Given this list of marker genes ZDHHC15, GBP4, PLPP5, GEM, TRAF6, TP63, MIA2 (MIA SH3 domain ER export factor 2), ARF3, VAMP1, SF3B1, CALML4, WDR82, COBL, MAN1C1, ZNF566, MAP3K8, RNF145, TGFBR3L, MACC1, DPP8, ETV1, IRF2BP2, NALCN, ADGRF5, CDY1B, NSD2, GUCY1A1, SLC2A1, NRAS, HIF1A, NOS1, MAP3K7, ANKRD1, SCN3A, RTL9, PABPC4L, CHRNA7, SULT1A4, RBM26, SV2A, PLS1, SCN9A, SCD5, NAP1L1, MORF4L2, CDY1, UCHL3, CBL, C5orf24, RFX7, SLITRK4 (NCBI Gene Id 139065), CDH23, TSHZ3, PSMD14, SPAM1, PREX2, ZNF101, NCOA2, ZHX1, MKLN1, HSDL2, KRBA2, ZNF568, AAK1, PTCHD4, RCAN2, EYA4, RAC1, RELCH, SPHKAP, KCNMB2, FAM43A, HECA, CNR1, MLLT11, here is a description of the gene set: studied in species Homo sapiens Genes predicted to be targets of miRBase v22 microRNA hsa-miR-8055 in miRDB v6.0 with MirTarget v4 prediction scores > 80 (high confidence targets). Human Gene Set: MIR8055 from publication Chen Y, Wang X (PMID 31504780)